The following is a description of a gene set: Any process that results in a change in state or activity of a cell or an organism (in terms of movement, secretion, enzyme production, gene expression, etc.) as a result of a prostagladin E stimulus. species: Mus musculus Mouse Gene Set: GOBP_RESPONSE_TO_PROSTAGLANDIN_E, and this is the list of marker genes: Ccl21e, Ccl19-ps3, Prkaa2, Ccl19, Ppp1r9b (NCBI Gene Id 217124), Akap8, Ptger1, Ptger2 (prostaglandin E receptor 2 (subtype EP2)), Ccl21d, Ccl21a, Ccl19-ps4, Prkaa1, Gnai1, Ccl21b, P2ry4, Ccl21f, Ccl19-ps5, Acaca, Aanat, Prkce, Ccl19-ps1, Cyp27b1, Tnfsf4, Tgfbr3, Scn11a, P2ry6, Akt1, Adcy6, Ptger4, Sfrp1, Oxt, Ccl19-ps6, Ccr7, Gnas, Pax6, A2m (NCBI Gene Id 232345)